Given this list of marker genes ST18, NRN1, THSD7A, PTPRK, NXPH4, DDIT4, ARL4D, EPHA7, ZFPM2, CNTNAP2, FEZF2, CALB2, NHLH2, CFAP298, CGA, NEUROD1, PCDH9, SNCB (NCBI Gene Id 6620), HPCA, HEY1, NHLH1 (nescient helix-loop-helix 1), ABRACL, AKT3, MYO6, HSPA1A, CADPS, here is a description of the gene set: Human Gene Set: ZHONG_PFC_C1_NEUROD1_POS_EXCITATORY_NEURON from publication Zhong S, Zhang S, Fan X, Wu Q, Yan L, Dong J, Zhang H, Li L, Sun L, Pan N, Xu X, Tang F, Zhang J, Qiao J, Wang X (PMID 29539641) species: Homo sapiens